The following is a description of a gene set: Human Gene Set: RHODES_CANCER_META_SIGNATURE Many studies have used DNA microarrays to identify the gene expression signatures of human cancer, yet the critical features of these often unmanageably large signatures remain elusive. To address this, we developed a statistical method, comparative metaprofiling, which identifies and assesses the intersection of multiple gene expression signatures from a diverse collection of microarray data sets. We collected and analyzed 40 published cancer microarray data sets, comprising 38 million gene expression measurements from >3,700 cancer samples. From this, we characterized a common transcriptional profile that is universally activated in most cancer types relative to the normal tissues from which they arose, likely reflecting essential transcriptional features of neoplastic transformation. In addition, we characterized a transcriptional profile that is commonly activated in various types of undifferentiated cancer, suggesting common molecular mechanisms by which cancer cells progress and avoid differentiation. Finally, we validated these transcriptional profiles on independent data sets. Genes commonly up-regulated in cancer relative to normal tissue, according to the meta-analysis of the OncoMine gene expression database. species: Homo sapiens from publication Rhodes DR, Yu J, Shanker K, Deshpande N, Varambally R, Ghosh D, Barrette T, Pandey A, Chinnaiyan AM (PMID 15184677), and this is the list of marker genes: MTHFD2, HSPD1, NCBP2, PLK1, RBM4, KDELR2, RFC4, HSPE1, AHCY, GFUS, HSP90B1, SSBP1, ILF2, MRPL3, SNRPF, PAFAH1B3, PSME2, MANF, ACLY, PPP2R5C (NCBI Gene Id 63377), SMARCA4, CCT4, MMP9 (NCBI Gene Id 4318), TUBB, OGT, KPNA2, E2F5, PTMA, CCT5, G3BP1, MRPS12, CBX3, COL1A2, TARS1, IFNGR2, UBE2S, TRAF4, COPB2, TPX2, IARS1, TGIF1, CDK1, LDHA (NCBI Gene Id 3939), SSR1, PCLAF, DVL3, SDHC (succinate dehydrogenase complex subunit C), EIF4A3, SOX4, CDKN3, NME1, SNRPE, NONO, FAP, HNRNPA2B1 (NCBI Gene Id 3181), HDAC1, NUP205, MCM3, CRIP2, PAICS, CANX, PRDX4, CKS2, PSMC4, TOP2A